Given this list of marker genes FCMR, KIAA0040 (NCBI Gene Id 9674), LTB, IARS1, CD72, POLR3E, JCHAIN, HLA-DOB, NT5C, BCL11A, FBL, IGKC, CCDC92, P2RX5, TMEM156, BIRC3, DSP (NCBI Gene Id 202512), EZR, BANK1, MICAL3, PRKD2, S1PR1, ABLIM1, EAF2, ABCB4, PRIM1, ERG28, SETBP1, AUTS2, BCS1L, TRAF5, PTPRCAP, GTPBP1, PRPS1, RRAS2, CD79B, PPP1R16B, BLNK, IGLJ3, IGHD, ACAP1, GNB5, IGLL3P, ITM2C, GGA2, PAX5 (NCBI Gene Id 5079), ADAM19, UBIAD1, QRSL1, TRIB2, SMYD2, POU2AF1 (NCBI Gene Id 5450), MS4A1, PCDH9, IGHM, AKR1B1, C10orf95-AS1, IGKV1D-13, GOLGA2P5, GTF3A, STAP1, TBC1D5, GNG7, ASNS, CCR7, SMAGP, EIF2D, RPS10P5, TCF3, ATIC, WDR74, JADE2, CD22, PKIG, ESYT1, SEPTIN6, FAM3C, RASGRP1, CD19, LBH, FBXW4, RUVBL1, GUSBP11, RASGRP3, RPA2, SLAMF1, PNOC, PARP1, HDHD3, ST6GAL1, VEGFB, ID3, CBX5, CD27, FCRL2, RABGEF1, LSM2, IGLV1-44, FCER2, EHD3, NUP88, OPTN, PTPRK, ZNF253, TSPAN3, RPSA, DPH5, PIM2, ANKEF1, CR2, SEL1L3, TLE5, ADD1, LIG1, ISG20, BEND5, BCL7A, ZHX2, CD81, KLHDC2, WASF1, TUT4, SPTBN1, TMEM243, MAPK13, FAM30A, RHOH, SHMT2, CD200, RPL18, CSGALNACT1, TLE1, GLS, RPL36, PDE4B, GPR18, CCR6, IGKV4-1, BMS1P20, IL16, ZBTB5, TCTN1 (tectonic family member 1), SYNPO, NXT1, LY9, MEN1, TOP3B, CXCR5, LARGE1, EVL, ODC1, CD24, OXCT1 (3-oxoacid CoA-transferase 1), SYNE2, AP1G2, PRKACB, TCL1A, MAGED1, NCK2, ATP2A3, PIK3C2B, SYBU, ZNF331, LIMS2, CD79A, FAM117A, VPREB3, MAP4K1, IL4R, ARID5B, ADPRM, HTRA2, SLC38A1, AEBP1, NFX1, SIDT1, SPIB, ITPR3, MCM2, TPD52, RPL6, MZB1, SP140, ITGB7, CTC1, DYRK4, PDLIM1, STK17A, SKAP1, RPL35, TSPAN13, BCL2, PJA1, DIPK1A, GVINP1, BACH2, RPA3, here is a description of the gene set: from publication Hutcheson J, Scatizzi JC, Siddiqui AM, Haines GK 3rd, Wu T, Li QZ, Davis LS, Mohan C, Perlman H (PMID 18275831) Human Gene Set: GSE10325_BCELL_VS_MYELOID_UP Gene expression profile studies have identified an interferon signature in whole blood or mononuclear cell samples from patients with systemic lupus erythematosus. This study was designed to determine whether specific lymphocyte and myeloid subsets freshly isolated from the blood of systemic lupus erythematosus patients demonstrated unique gene expression profiles compared to subsets isolated from healthy controls. Genes up-regulated in comparison of healthy B cells versus healthy myeloid cells. species: Homo sapiens